Given this list of marker genes SV2C, SV2B, VAMP1, VAMP2, SV2A, here is a description of the gene set: Human Gene Set: REACTOME_TOXICITY_OF_BOTULINUM_TOXIN_TYPE_D_BOTD species: Homo sapiens Toxicity of botulinum toxin type D (botD)